The following is a description of a gene set: studied in species Mus musculus Mouse Gene Set: GOBP_NEGATIVE_REGULATION_OF_GLIAL_CELL_DIFFERENTIATION Any process that stops, prevents, or reduces the frequency, rate or extent of glia cell differentiation., and this is the list of marker genes: Nf1, Ctnnb1, Nkx6-1, Nr2e1, Dll3, Lingo1, Drd3, F2, Casz1, Tmem98, Atf5, Id4, Daam2, Id2, Hes1, Bmp4, Ldlr, Dab1, Trem2, Sirt2, Hmga2, Ntrk3, Dlx2, Lin28a, Mecp2, Nkx6-2, Notch1, Mycn, Hes5, Nr1d1, Dusp10, Kdm4a, Gpr37l1, Mbd1, Nog, Dlx1, Fgfr3